The following is a description of a gene set: from publication Cui A, Huang T, Li S, Ma A, Pérez JL, Sander C, Keskin DB, Wu CJ, Fraenkel E, Hacohen N (PMID 38057668) Mouse Gene Set: CUI_T_CELL_GD_IL17A_RESPONSE_DN Genes negatively differentially expressed in cell type: γδ T cell upon treatment with cytokine: IL-17A in mouse lymph nodes in vivo. species: Mus musculus Cytokines mediate cell-cell communication in the immune system and represent important therapeutic targets. A myriad of studies have highlighted their central role in immune function, yet we lack a global view of the cellular responses of each immune cell type to each cytokine. To address this gap, the authors created the Immune Dictionary, a compendium of single-cell transcriptomic profiles of more than 17 immune cell types in response to each of 86 cytokines (>1,400 cytokine-cell type combinations) in mouse lymph nodes in vivo. A cytokine-centric view of the dictionary revealed that most cytokines induce highly cell-type-specific responses. For example, the inflammatory cytokine interleukin-1β induces distinct gene programmes in almost every cell type. A cell-type-centric view of the dictionary identified more than 66 cytokine-driven cellular polarization states across immune cell types, including previously uncharacterized states such as an interleukin-18-induced polyfunctional natural killer cell state., and this is the list of marker genes: Jun, Hspa1b, Klf2, Fos, Klf6